The following is a description of a gene set: It has been recently shown that cannabinoids, the active components of marijuana and their derivatives, inhibit cell cycle progression of human breast cancer cells. Here we studied the mechanism of Delta(9)-tetrahydrocannabinol (THC) antiproliferative action in these cells, and show that it involves the modulation of JunD, a member of the AP-1 transcription factor family. THC activates JunD both by upregulating gene expression and by translocating the protein to the nuclear compartment, and these events are accompanied by a decrease in cell proliferation. Of interest, neither JunD activation nor proliferation inhibition was observed in human non-tumour mammary epithelial cells exposed to THC. We confirmed the importance of JunD in THC action by RNA interference and genetic ablation. Thus, in both JunD-silenced human breast cancer cells and JunD knockout mice-derived immortalized fibroblasts, the antiproliferative effect exerted by THC was significantly diminished. Gene array and siRNA experiments support that the cyclin-dependent kinase inhibitor p27 and the tumour suppressor gene testin are candidate JunD targets in cannabinoid action. In addition, our data suggest that the stress-regulated protein p8 participates in THC antiproliferative action in a JunD-independent manner. In summary, this is the first report showing not only that cannabinoids regulate JunD but, more generally, that JunD activation reduces the proliferation of cancer cells, which points to a new target to inhibit breast cancer progression. Genes up-regulated in EVSA-T cells (breast cancer) after treatment with 3 micromolar THC (delta-9-tetrahydrocannabinol) for 24 h. Human Gene Set: CAFFAREL_RESPONSE_TO_THC_24HR_3_UP from publication Caffarel MM, Moreno-Bueno G, Cerutti C, Palacios J, Guzman M, Mechta-Grigoriou F, Sanchez C (PMID 18454173) species: Homo sapiens, and this is the list of marker genes: EIF3I, LRRFIP1, CCNG1, SRSF5, SEC61A1, ABCC12, RPS2 (NCBI Gene Id 6187), CNBP